Given this list of marker genes RPS28, HS2ST1, JARID2, NANS, ALG11, PEX1, ANKRD11, FREM2, SLC25A24, PPP1CB, NOVA2, SPECC1L, RPS15A, APC2, THOC6, TBC1D20, PRKD1, FLNA, XRCC4, HYOU1, SOX11, RAB3GAP2, SPOP, SMC3, RPS10, RALGAPA1, RAB18, MAP3K7, DHX30, RPS26 (ribosomal protein S26), ADA2, SOX4, RPL31, TWIST2, NBN, POLR1B, GATA1, RPL11, VPS33A, ABCC9, PIGG, POLR1D, PIGA (phosphatidylinositol glycan anchor biosynthesis class A), TECPR2, POLR1C (RNA polymerase I and III subunit C), NOTCH2, PIGK, SETD2, NSD2, PPARG, CPLX1, KREMEN1, AGPAT2, SETD5, EMC1, PPP1R15B (protein phosphatase 1 regulatory subunit 15B, NCBI Gene Id 84919), PEPD, CDK5 (NCBI Gene Id 1020), STAG2, TBC1D24, IFIH1, PEX6, AFG2B, SMO, ADNP, RPL8, CREBBP, RPL18, PIK3C2A, H1-4, UBAP2L, GDF11, EBF3, MAPRE2, VPS13B, SMARCC2, TSR2, EFNB1, TAF6, ERI1, RPL26, WNT4, MID1, MAB21L1, MAN2B1, DOCK7, SMARCE1, NELFA, SMC1A, ARID1B, CIT, CWC27, EFEMP1, ASXL1, FAT4, NUDT2, SATB1, HSPG2, ALX3, FGFR3, FKRP, FGD1, PACS1, ZNF699 (zinc finger protein 699), ERMARD, RPS17, ADARB1, FOS, TBL1XR1, CAPRIN1 (cell cycle associated protein 1), COG5, SMARCD1, RPS24, SH2B1, RPS19, SOS1, STT3A (STT3 oligosaccharyltransferase complex catalytic subunit A), RPL15, KCNH1, BSCL2, INSR, ARX, TCF12, ALX1 (NCBI Gene Id 8092), IGF1, RPS7, ZIC1, MEIS2, PGAP1, AIFM1, DPH2, EP300, BICRA, TRIO, FRMD4A, SMARCA4, NIPBL, RAD21, LRP2, CNTNAP2, TRPM3, UGP2, TBX15, CTBP1, ATP6V1B2, DPF2, LIG4, TBX2 (T-box transcription factor 2), CLCN3, ZFX, KCNN3, NSUN2, TWIST1, H3-3A, CCNK, SVBP, COG7, RPS27, RPL5, KDM1A, SMARCB1, MED13L, TRMT10A, SIN3A, RPS20, DOCK6, TMCO1, RERE, CDC42BPB, GNB2, BRCA1, FGFR2, SLC26A2, NEPRO, BRD4, NSD1, HDAC8, MEGF8, GMPPA, H4C5, PPP1R13L, KCNJ8, RPL35A, LMX1B, LRPPRC, TTC5, ARID2, SMARCA2, SPEN, ANKRD17, RPL27, RPS29, SYT1, RPL35, CPOX (NCBI Gene Id 201541), FILIP1, ASH1L, SLC35C1, ARID1A, SLC9A7, DEAF1, DPM2, HEATR3, RHOBTB2, LETM1, CAV1, RPL9, RBL2, CDH1, CAVIN1, PRDM13, SLC12A6, ZC4H2, DLX4, SMPD4, FRAS1, TCOF1, MED12, here is a description of the gene set: species: Homo sapiens Abnormality of the frontal hairline An anomaly in the placement or shape of the hairline (trichion) on the forehead, that is, the border between skin on the forehead that has head hair and that does not. Human Gene Set: HP_ABNORMALITY_OF_THE_FRONTAL_HAIRLINE